Given this list of marker genes Lef1, Plk3, Zfp704, Cbx2, Nr2f1, Nxn, Kdm5a, Tle1, Pter, Setd5, Pard3, Chd7, Myb, Col18a1, Ccdc80, Vegfc, Fhl1, Bcan, Nfatc4, Slc26a7, Emx2, Pdcd4, Fgfr3, Lhx2, Epdr1, Mt1, Gadd45g, Flrt3, Suz12 (SUZ12 polycomb repressive complex 2 subunit), Nr0b1, Fgfr2, Fzd9, Nr4a2, Bmp4, Ncor2, Pak3, Tgif1, Eed, Frzb, Tmem47, Nfatc2, Tbc1d4, Rfx4, Tshz1, Tgfb2, here is a description of the gene set: Genes expressed at higher levels in caudal regions beginning in the ventricular zone, in some cases extending into the subventricular zone, intermediate zone, and cortical plate of embryonic day 14.5 mouse cortex. studied in species Mus musculus from publication Bedogni F, Hevner RF (PMID 34321999) Mouse Gene Set: HEVNER_CORTEX_CAUDAL_VENTRICULAR_ZONE